Given this list of marker genes Gsk3b, Adar, Prkaa2, Stk4, Kcnn4, Atf2, Lims1, Atf7, Fas, Ppara, Casp8, Cflar, Arf6, Gsn, Bcl2l1, Igf1r, Rb1, Casp6, Selplg, Stk3, Krt18, Mtch2, Prkaa1, Bid, Krt8, Pik3cg, Dnmt3a, here is a description of the gene set: Mouse Gene Set: GOBP_HEPATOCYTE_APOPTOTIC_PROCESS Any apoptotic process in a hepatocyte, the main structural component of the liver. species: Mus musculus